The following is a description of a gene set: mouse primary BMDCs were stimulated with tlr ligands and gene expression changes were profiled on Affymetrix arrays studied in species Homo sapiens Genes up-regulated in comparison of dendritic cells (DC) stimulated with Pam3Csk4 (TLR1/2 agonist) at 12 h versus DC cells stimulated with CpG DNA (TLR9 agonist) at 12 h. Human Gene Set: GSE17721_PAM3CSK4_VS_CPG_12H_BMDC_UP from publication Amit I, Garber M, Chevrier N, Leite AP, Donner Y, Eisenhaure T, Guttman M, Grenier JK, Li W, Zuk O, Schubert LA, Birditt B, Shay T, Goren A, Zhang X, Smith Z, Deering R, McDonald RC, Cabili M, Bernstein BE, Rinn JL, Meissner A, Root DE, Hacohen N, Regev A (PMID 19729616), and this is the list of marker genes: TRAM1, KRTAP4-12, EIF5, SFXN3, FUOM, SPATS2, WRNIP1, SIAE, TMEM205, RPA3, RPL13A, DNAJC3, ETFDH, LYRM2, DHRS1, BCAS3, HINT1, STUB1, EIF3I, CX3CR1, MRPL41 (mitochondrial ribosomal protein L41), PYY, TECTA, NDUFS8, HPF1, TIMM8A, NAB2, PEX2, MSRB1, MBTD1, SELENOS, NDUFA11, MRPL57, ANAPC15, EBPL, ACADM, PPP1CC, RNF26, SAYSD1, TCF21, ADGRA3, CLEC4D, CIB2, NDUFS6, H2AX, RPL37A, VOPP1 (VOPP1 WW domain binding protein), YPEL3, CYP51A1, MPV17 (mitochondrial inner membrane protein MPV17), SGIP1, RPL7A, MICOS13, OLA1, PRR15, AFM, NDUFA8, CXCL2, ATXN10, GPR85, PREB, NUP42, RBM3, EIF4EBP2, RPL22, HEXIM1, MRPL37, CSNK1E, MFSD10, LAGE3, MRPL45, TIMM10B, USP34, PRKAG1, EMG1, TIMM17B, BBLN, POLR2G, LTA4H, RORC, PUM3, ABCC1, MRPL15, CISD1, MYADM, AGBL5, SAMM50, NPM1 (NCBI Gene Id 4869), EIF5A, LPGAT1 (lysophosphatidylglycerol acyltransferase 1), TNRC6B, PAG1, MYLK2, CSE1L, YAF2, TMEM97, NUDT16L1, SIGLEC7, GTF2H3, CREB3L2, CYB5R1, ACBD6, FKBP4, IDH1, TRIAP1, LMNB2, GGH, PGP, MTCH2, NDUFA6, TSSK6, SRP19, PARK7, NIN, NSMF, MRRF, CRYL1, CCDC12, COX8A, C19orf53, NDUFA4, DYNLT3, ECI2, NCAPH2, CYB5A (cytochrome b5 type A), FRRS1, INTS6L, DPY30, RNASET2, VDAC1, SLC39A6, PDCD5, EMSY, FAM110C, RPL27, KLHL2 (NCBI Gene Id 11275), C4BPB (NCBI Gene Id 725), TST, EXTL2, RPL31, TCEAL9 (NCBI Gene Id 51186), RCHY1, PHB1, PHTF2, SFRP2, FASTKD5, COL9A1, EIF4A3, CCDC91, LMAN2, PRKRA, CDK2AP1 (cyclin dependent kinase 2 associated protein 1), C15orf40, GALC, DUSP6, RBBP9, AVPI1, PARVG, LTB4R, ETFBKMT, ERI3 (NCBI Gene Id 79033), CDK2AP2, SLC12A6, APRT, GNG10, YIF1A, SLAIN2, OAZ1, ZMPSTE24, SLC16A3, LRBA, FPR2, TPGS2, POLR2E (NCBI Gene Id 5434), EFNA1, GPX1, GPSM3, POP5, PRXL2A, PURA, SFTPB, PTCH1, TM2D2, SEC31A, MRPS28, WDR12, TMEM63A, GRK5, MANF (mesencephalic astrocyte derived neurotrophic factor), N4BP3, NDUFA9, SLC44A1, PRAF2, SGF29, HADH, TMEFF1, S100A6, LRPPRC, WBP1, EMB